The following is a description of a gene set: Vertical nystagmus may present with either up-beating or down-beating eye movements or both. When present in the straight-ahead position of gaze it is referred to as upbeat nystagmus or downbeat nystagmus. studied in species Homo sapiens Human Gene Set: HP_VERTICAL_NYSTAGMUS Vertical nystagmus, and this is the list of marker genes: PRRT2, RFC1, PLA2G6, CACNA1A (NCBI Gene Id 773), TTBK2, ALX4, ECHS1, NDUFS8, U2AF2, TTR, FAT2, PET100, FGF14, TMEM106B, ANO10, ATP1A2, SCN1A, PIGN, PEX5, MRE11, COQ2, PIGQ, AHDC1